The following is a description of a gene set: Mouse Gene Set: chr14E5 studied in species Mus musculus, and this is the list of marker genes: Gm15422, Gm17082, Ipo5, AA536875, Tm9sf2, Pcca, Zic5, Gm25272, Clybl, Itgbl1, Stk24, 4930594M22Rik, 1700108J01Rik, Gm5089, 1700024B18Rik, Gm10837, Gpr183, Gpr18, Or6c220-ps1, B930095G15Rik, Gm6254, Tmtc4, Ubac2, Gm9395, A330035P11Rik (NCBI Gene Id 319727), 2610035F20Rik, Gm9399, Gm18143, Fgf14, Dock9, 1810041H14Rik, Btf3-ps4, Ggact, Farp1, 4930404O17Rik, Nalcn, Gm33299, Zic2, Timm8a2 (translocase of inner mitochondrial membrane 8A2), Gm4529 (NCBI Gene Id 100043577), Slc15a1